Given this list of marker genes RGS7BP, ITSN1, GIPC1, DRD2, ZDHHC12, DOCK10, APBA1, DDN, GPM6A, GRIA3, HIP1R, PPFIA1, NTRK2, ATP6AP2, GABBR1, SLC9A5, PALM, LZTS1, PTCHD1, OPRD1, FMR1, ATP2B2, PPP1CA, SHANK1, ABI3, HPCA, PTPRO, ARC, PPFIA2, PDE4B, SHISA7, GRIA4, ZNF804A, GRIA2, PRRT2, BAIAP2, PPP1R9A, FCGR2B (Fc gamma receptor IIb), GABRB3, CAMK2A, APBA2, CTTNBP2, GRID2, NTSR1, NR1D1, PPP1R9B, SHISA6, SEZ6, GRM3, NOS1, ITPKA, MYL7, KCND3, ARFGEF2, ABHD17B, CPEB4, SYNPO, HAP1, ARHGAP32, OPHN1 (oligophrenin 1), CNIH2, DRD1, ABHD17C, ANKS1B, NGFR, SLC1A1 (solute carrier family 1 member 1), SEPTIN11, FXR1, ITGA8, ACTN2, GRIN1, GABRA1, GPHN, SYNDIG1, GABRB2, IGF2BP1, P2RX6, ABI2 (NCBI Gene Id 10152), SLC8A2, GRID1, LZTS3, DTNBP1, TANC2, EPHA4, KCNJ2, KCND2, APBA3, SRGAP2, ZMYND8 (NCBI Gene Id 55497), GPER1, GRIN2A, RGS14, CTTN, MPP2, RHOA, DGKI, CRYAB, LPAR1, KCNC3, MAP1B, PRKAR2B, ARF4, GRIA1, AKAP5, CLCN2, PALMD, GABRG2, TENM2, SHISA9, STRN, CD3E, EEF2K, MAPT, DVL1, ATP1A2, SYT11, NLGN1, CRIPT, RPH3A, PSD, ABR, SLC8A3, ASIC2, ABHD17A, EEA1, ITGB1, PDLIM4, FBXO2, PPP1CC, STX4, MT3, MYH10, LAMA2, NEURL1, KCNA4 (NCBI Gene Id 3740), ARHGAP33, ADORA1, BCR, STRN4, TRPV1, KIF3B, SHISA8, FRMPD4, GRM5, DAGLA, SHANK3, HOMER1, DNAJB1, DLG4, CFL1, CDK5R1, SIPA1L1, KCNN2, PPP3CA, FARP1, EPHB2, SORCS2, DNM3, MTMR2, KCND1, APP, PTEN, SHANK2, NRGN, LRRC4, ARHGAP44, ADGRB1, ALS2, DIP2A, here is a description of the gene set: A small membranous protrusion, often ending in a bulbous head and attached to the neuron by a narrow stalk or neck. Human Gene Set: GOCC_NEURON_SPINE species: Homo sapiens